Given this list of marker genes P4HB (prolyl 4-hydroxylase subunit beta), APOB, APOC1, APOC4, MTTP, here is a description of the gene set: VLDL assembly Human Gene Set: REACTOME_VLDL_ASSEMBLY studied in species Homo sapiens